Given this list of marker genes Cyp27b1, Gnas, Gata3, Fgfr1, Fgfr4, Trpv6, Vdr, here is a description of the gene set: studied in species Mus musculus Mouse Gene Set: GOBP_PARATHYROID_HORMONE_SECRETION The regulated release of parathyroid hormone into the circulatory system.